The following is a description of a gene set: The human SLC26 gene family consists of eleven members which encode multifunctional anion exchangers.These exchangers are capable of transporting a variety of anions such as sulphate, bicarbonate, oxalate, hydroxyl, formate, iodide and chloride. SLC26 members can be grouped according to functional similiarities and three groups can be classified this way. Group 1 are selective sulphate transporters and include SLC26A1 and 2. Group 2 are Cl-/HCO3- exchangers and include SLC26A3, 4 and 6. Group 3 function as ion channels and include SLC26A7 and 9. studied in species Homo sapiens part of: SLC-mediated transport of inorganic anions Reactome Pathway: Inorganic anion exchange by SLC26 transporters, and this is the list of marker genes: SLC26A7, SLC26A4, SLC26A11, SLC26A1, SLC26A6, SLC26A3, SLC26A9, SLC26A2